The following is a description of a gene set: Binding to a lipase. studied in species Mus musculus Mouse Gene Set: GOMF_LIPASE_BINDING, and this is the list of marker genes: Clps, Apoa5, Plin5, Gpihbp1, Lrpap1, Faf2, Apob